The following is a description of a gene set: from publication Yosef N, Shalek AK, Gaublomme JT, Jin H, Lee Y, Awasthi A, Wu C, Karwacz K, Xiao S, Jorgolli M, Gennert D, Satija R, Shakya A, Lu DY, Trombetta JJ, Pillai MR, Ratcliffe PJ, Coleman ML, Bix M, Tantin D, Park H, Kuchroo VK, Regev A (PMID 23467089) Genes up-regulated in CD4 T helper cells (20h): Th0 versus TGFB1 and IL6. Human Gene Set: GSE43955_TH0_VS_TGFB_IL6_TH17_ACT_CD4_TCELL_20H_UP studied in species Homo sapiens Despite their enormous importance, the molecular circuits that control the differentiation of Th17 cells remain largely unknown. Recent studies have reconstructed regulatory networks in mammalian cells, but have focused on short-term responses and relied on perturbation approaches that cannot be applied to primary T cells. Here, we develop a systematic strategy – combining transcriptional profiling at high temporal resolution, novel computational algorithms, and innovative nanowire-based tools for performing gene perturbations in primary T cells – to derive and experimentally validate a temporal model of the dynamic regulatory network that controls Th17 differentiation. The network is arranged into two self-reinforcing and mutually antagonistic modules that either suppress or promote Th17 differentiation. The two modules contain 12 novel regulators with no previous implication in Th17 differentiation, which may be essential to maintain the appropriate balance of Th17 and other CD4+ T cell subsets. Overall, our study identifies and validates 39 regulatory factors that are embedded within a comprehensive temporal network and identifies novel drug targets and organizational principles for the differentiation of Th17 cells., and this is the list of marker genes: GABRR2 (NCBI Gene Id 2570), GTF3C1, IL16, TXNDC12, EPHA6, HOXA4, ALKBH5, EIF4G1, PTK2B, NAB2, FZD9, GC (GC vitamin D binding protein), MEIS1, PRPS2, PPRC1, CETN3 (NCBI Gene Id 1070), GEM, LHCGR, PDPN, HNRNPUL2, FECH, ZNF146, FBN1, ECM1, IL1R2, HP1BP3, POLDIP3, PCDHA10, PTPRR, HEPH, JUNB, GPR37, CDC23, COX14, TARBP2, FCRLA, ANAPC16, MRPL50, PLIN4, CCNG2, AGXT, TSPAN12, RPP21, BCL6, DACH1, RARS1, NR4A1, RPS10, MTFR1L, PITHD1, FAM110A, IL1A, CD74, RBM14, HOXA11-AS, PPIH, CITED1, PPARD, POU3F3, MDM2, ASCL2, TKTL1, BMP6, FNDC1, MTMR9, SCAMP1 (NCBI Gene Id 9522), TCTA, MYORG, KRT27, TUBB2A, CXCL2, CYSTM1, RALA, RLIM, ACP5, SEMA3C, MAP2K1, ASIP, PAPOLA, DDX3Y, ADISSP, ATRX (NCBI Gene Id 6475), CYP2J2, TNF, RAC3, SLC27A1, TFAP2A, ZC3H12C, MSL2, DKK3, UCHL1, PDIA3, GK, CHPT1, SAYSD1, TNFAIP6, IER2, INO80C, SCOC, SERPINB5, REX1BD, CRADD (CASP2 and RIPK1 domain containing adaptor with death domain), UQCC5, PKD2, WASF2, GPAT4, AEBP1, UBE2F, SIM1, SLC5A6, KRR1, CYBB, CSTF1, ATXN2, PDRG1, MBP, B2M, SEBOX, SYS1, H3C14, SRPRA, CXCL3 (NCBI Gene Id 2921), ASGR1, SLC25A47, SMC4, BRWD3, POLR3A, GSDME, CEBPB, GALNT3, IRS1, DVL3, CTNNAL1, U2AF1, KLF10, STX1B, MDFI, NAV1, RNF4, PPL, IL10, ZFR, ZNF362, LHX3, PEBP1, CCL5, WDR74 (WD repeat domain 74), M6PR, VASP, PALD1, CNN1 (calponin 1), MYH7, CITED2, COL13A1, R3HDM1, RDH16, ESR2, RPA2, TBRG1, SGK1, MRTO4, STK16, CCR6, DBN1, TNKS2, CD68, POLE4, RHOB, MXD1, ADRM1, CIZ1 (NCBI Gene Id 25792), NFKBIZ, RABEPK, C5orf34, ZNF260, RAD9A, IDS, TBPL1, CSNK1E, NNMT, KMT2E, GLRX, CYB5R3, VAC14, IFRD1 (NCBI Gene Id 95049), FOS, NEU1, ST3GAL2, TCAP, SIX1, PPP3CA, POLR2L, TSR1, PCBP1, SGCG, TMEM131, GFI1, ANKH, SNAPC3, AMPD3 (adenosine monophosphate deaminase 3)